The following is a description of a gene set: Mouse Gene Set: GOCC_PRESYNAPTIC_ENDOSOME studied in species Mus musculus An endosome present in the presynapse that fuses with endocytic vesicles arising in the presynaptic endocytic zone. This organelle is believed to be involved in regeneration of synaptic vesicles., and this is the list of marker genes: Vac14, Rab7, Ctsd, Vamp4, Pik3c3, Snx4, Eea1, Ap3d1, Rabgef1